Given this list of marker genes SLC9A6, here is a description of the gene set: part of: SLC transporter disorders SLC9A6 encodes the sodium/hydrogen exchanger 6 NHE6, a protein ubiquitously expressed but most abundant in mitochondria-rich tissues such as brain, skeletal muscle and heart. It is located on endosomal membranes and thought to play a housekeeping role in pH homeostasis in early endosomes. It mediates the electroneutral exchange of protons for Na+ and K+ across the early and recycling endosome membranes. Defects in SLC9A6 can cause mental retardation, X-linked, syndromic, Christianson type (MRXSCH; MIM:300243), a syndrome characterised by profound mental retardation, epilepsy, ataxia and microcephaly. MRXSCH shows phenotypic overlap with Angelman syndrome. Reactome Pathway: Defective SLC9A6 causes  X-linked, syndromic mental retardation,, Christianson type (MRXSCH) studied in species Homo sapiens